The following is a description of a gene set: Endoplasmic reticulum stress response in coronavirus infection Human Gene Set: WP_ENDOPLASMIC_RETICULUM_STRESS_RESPONSE_IN_CORONAVIRUS_INFECTION species: Homo sapiens, and this is the list of marker genes: DDIT3, EIF2AK1, EIF2AK3, PPP1CC, MAP1LC3A, PPP1R12A, PPP1R12B, PPP1R3A, ERN1, PPP1R1C, PPP1R16B, PPP1R16A, PPP1R15B, ATF4, HSPA5, PPP1R10, PPP1CB, PPP1R1A, PPP1R3C, PPP1R13B, PPP1R15A, MBTPS1, EIF2AK2, MBTPS2, XBP1, ATF6, PPP1R2, BCL2, PPP1R9A, EIF2S1, PPP1R7, PPP1R1B, PPP1R3B, PPP1R14D, PPP1R11, PPP1R14B, PPP1R3D, PPP1R14A, PPP1R8 (NCBI Gene Id 5511), MAPK8, PPP1R12C, PPP1CA, PPP1R3G, PPP1R3E, PPP1R3F, PPP1R14C